The following is a description of a gene set: species: Mus musculus Mouse Gene Set: GOBP_PROSTAGLANDIN_TRANSPORT The directed movement of prostaglandins into, out of or within a cell, or between cells, by means of some agent such as a transporter or pore., and this is the list of marker genes: Slc22a8, Nos2, Ptgs2, Abcc4, Slc22a2, Pla2g4a, Il1a, Slco3a1 (solute carrier organic anion transporter family, member 3a1), Acsl4, Pla2g3, Tnfrsf11a, Abcc2, Slc22a22, P2rx7, Slco4a1 (NCBI Gene Id 28251), Slc22a7, Slco2a1, Mif, P2ry2, Map2k6, Pla2g10, Oxt, Atp5pf, Edn1, Il1b, Tnfsf11, Slc22a1, Lep, Slc22a6 (NCBI Gene Id 18399), Ptges, Mapk9